Given this list of marker genes SERPINA1, OAS2, C9, HLA-B, HLA-DRB1, GM2A, EEF1A1, TAPBP, B2M, IFI44, ISG15, CCL5, HLA-C, IFIT1, PSME2, LYZ, TAP1, CD74, IFI16, CXCL1, IFI27, HLA-E, IFITM2, FTH1, HLA-DQB1, CD59, EIF3E, CXCL9, HLA-DPB1, HLA-A, here is a description of the gene set: studied in species Homo sapiens from publication Kim M, Kim JH, Jang HR, Kim HM, Lee CW, Noh SM, Song KS, Cho JS, Jeong HY, Hahn Y, Yeom YI, Yoo HS, Kim YS (PMID 18757430) Human Gene Set: KIM_LRRC3B_TARGETS Leucine-rich repeat-containing 3B (LRRC3B) is an evolutionarily highly conserved leucine-rich repeat-containing protein, but its biological significance is unknown. Using restriction landmark genomic scanning and pyrosequencing, we found that the promoter region of LRRC3B was aberrantly methylated in gastric cancer. Gastric cancer cell lines displayed epigenetic silencing of LRRC3B, but treatment with the DNA methylation inhibitor 5-aza-2'-deoxycytidine and/or the histone deacetylase inhibitor trichostatin A increased LRRC3B expression in gastric cancer cell lines. Real-time reverse transcription-PCR analysis of 96 paired primary gastric tumors and normal adjacent tissues showed that LRRC3B expression was reduced in 88.5% of gastric tumors compared with normal adjacent tissues. Pyrosequencing analysis of the promoter region revealed that LRRC3B was significantly hypermethylated in gastric tumors. Stable transfection of LRRC3B in SNU-601 cells, a gastric cancer cell line, inhibited anchorage-dependent and anchorage-independent colony formation, and LRRC3B expression suppressed tumorigenesis in nude mice. Microarray analysis of LRRC3B-expressing xenograft tumors showed induction of immune response-related genes and IFN signaling genes. H&E-stained sections of LRRC3B-expressing xenograft tumors showed lymphocyte infiltration in the region. We suggest that LRRC3B is a putative tumor suppressor gene that is silenced in gastric cancers by epigenetic mechanisms and that LRRC3B silencing in cancer may play an important role in tumor escape from immune surveillance. Immune response genes up-regulated in zenograft tumors formed by SNU-601 cells (gastric cancer) made to express LRRC3B.